Given this list of marker genes GNA13, STAT4, GZMA, CD63, EIF2AK2, APBA2, VAV2, PTPN22, NOTCH1, ZFAND5, CRAT, SERPINB2, XBP1, CES1, TLX2, SH3BP1, CD14, KLF1, HBEGF, RBPJ, HNF4A, HOXD12, CCL2, MID1, SMAD4, YES1, HSPA2, HOXB4, PPM1G, KIF1B, CITED2, PSMC4, PLA2G7, YBX1 (Y-box binding protein 1), FOXD3, PDE1B, VCAM1, FOSL2, NFATC3, FOS, ZBTB17, HNF1A, CTLA4, here is a description of the gene set: Genes down-regulated during myeloid differentiation induced by tretinoin (ATRA) and IL3 in the EML cell line (myeloid progenitor). studied in species Mus musculus With the goal of creating a resource for in-depth study of myelopoiesis, we have executed a 2-pronged strategy to obtain a complementary DNA (cDNA) clone set enriched in hematopoietic genes. One aspect is a library subtraction to enrich for underrepresented transcripts present at early stages of hematopoiesis. For this, a hematopoietic cDNA library from primary murine bone marrow cells enriched for primitive progenitors was used as tester. The subtraction used 10 000 known genes and expressed sequence tags (ESTs) as driver. The 2304 randomly picked clones from the subtracted cDNA libraries represent 1255 distinct genes, of which 622 (50%) are named genes, 386 (30%) match uncharacterized ESTs, and 247 (20%) are novel. The second aspect of our strategy was to complement this subtracted library with genes known to be involved in myeloid cell differentiation and function. The resulting cDNAs were arrayed on polylysine-coated glass slides. The microarrays were used to analyze gene expression in primary and cultured murine bone marrow-derived progenitors. We found expression of various types of genes, including regulatory cytokines and their receptors, signal transduction genes, and transcription factors. To assess gene expression during myeloid differentiation, we examined patterns of change during induced differentiation of EML cells. Several hundred of the genes underwent fluctuations in expression level during myeloid cell differentiation. The complete database, accessible on the World Wide Web at http://yale130132115135.med.yale.edu/, allows for retrieval of information regarding these genes. Our microarray allows for genomewide expression analysis of myeloid stem cells, which will help in defining the regulatory mechanisms of stem cell differentiation. Human Gene Set: MA_MYELOID_DIFFERENTIATION_DN from publication Ma X, Husain T, Peng H, Lin S, Mironenko O, Maun N, Johnson S, Tuck D, Berliner N, Krause DS, Perkins AS (PMID 12130493)